Given this list of marker genes Hal, Hdc, Ftcd, Uroc1, Amdhd1, here is a description of the gene set: Mouse Gene Set: GOBP_L_HISTIDINE_CATABOLIC_PROCESS species: Mus musculus The chemical reactions and pathways resulting in the breakdown of L-histidine, 2-amino-3-(1H-imidazol-4-yl)propanoic acid.